The following is a description of a gene set: Systems biology is an approach to comprehensively study complex interactions within a biological system. Most published systems vaccinology studies have utilized whole blood or peripheral blood mononuclear cells (PBMC) to monitor the immune response after vaccination. Because human blood is comprised of multiple hematopoietic cell types, the potential for masking responses of under-represented cell populations is increased when analyzing whole blood or PBMC. To investigate the contribution of individual cell types to the immune response after vaccination, we established a rapid and efficient method to purify human T and B cells, natural killer (NK) cells, myeloid dendritic cells (mDC), monocytes, and neutrophils from fresh venous blood. Purified cells were fractionated and processed in a single day. RNA-Seq and quantitative shotgun proteomics were performed to determine expression profiles for each cell type prior to and after inactivated seasonal influenza vaccination. Our results show that transcriptomic and proteomic profiles generated from purified immune cells differ significantly from PBMC. Differential expression analysis for each immune cell type also shows unique transcriptomic and proteomic expression profiles as well as changing biological networks at early time points after vaccination. This cell type-specific information provides a more comprehensive approach to monitor vaccine responses. from publication Hoek KL, Samir P, Howard LM, Niu X, Prasad N, Galassie A, Liu Q, Allos TM, Floyd KA, Guo Y, Shyr Y, Levy SE, Joyce S, Edwards KM, Link AJ (PMID 25706537) studied in species Homo sapiens Human Gene Set: HOEK_MYELOID_DENDRITIC_CELL_2011_2012_TIV_ADULT_1DY_DN Genes down-regulated in myeloid dendritic cell 1d vs 0d in adults after exposure to 2011-2012 trivalent inactivated vaccine (A/California/7/09 (H1N1), A/Perth /16/2009 (H3N2), B/Brisbane/60/2008), time point 1D. Comment: Down-regulated DE RNA transcripts (down >= 1.5x) shared between both TIV-vaccinated donors, and this is the list of marker genes: SH3RF3, ZBTB7C, NRXN2, NOTCH3, GFI1B, PPP1R35